Given this list of marker genes SLC2A5 (solute carrier family 2 member 5), SLC25A5, SLC25A16, TCN1 (NCBI Gene Id 6947), ALOX5AP, RLBP1, TNC, AKR1C2, SLC2A3, FTH1, HSP90B1, AMBP, UCP1, PPBP, AKR1C1 (aldo-keto reductase family 1 member C1), VWF, UCP2, LCN2, here is a description of the gene set: Human Gene Set: MODULE_311 Genes in the cancer module 311. species: Homo sapiens